The following is a description of a gene set: from publication Chen Y, Wang X (PMID 31504780) studied in species Homo sapiens Genes predicted to be targets of miRBase v22 microRNA hsa-miR-3191-5p in miRDB v6.0 with MirTarget v4 prediction scores > 80 (high confidence targets). Human Gene Set: MIR3191_5P, and this is the list of marker genes: PARP9, SHISA7 (shisa family member 7), RICTOR, KCNRG, MAPK1, TMEM70, ATXN1, BTRC (NCBI Gene Id 8945), ARCN1, SLC35B4, ADGRF1, MICAL2, DESI1, MYO1C, RNGTT, METTL25B, MTM1, ZSWIM5, TRIM39, CD34, MRAS, ARID5B, UNC5C (unc-5 netrin receptor C), ZNF322, EPHB3, FAS, CLCN5, WDHD1, DDHD1, SELENOI, AQP9, GLS2, CALCR (NCBI Gene Id 799), ALCAM (NCBI Gene Id 214), OTUD1, SLC2A5 (solute carrier family 2 member 5), CMKLR1, SDK2, IQCJ-SCHIP1, PCDH7, NSL1, XPO4, BBX, KCTD15, NFATC3, DPF2, ZNF839, TMPRSS11D, TRABD2B, MAT2A, CERS6, COL14A1, STRADA, SEZ6L, LAIR1 (NCBI Gene Id 3903), TAF12, AFG2A, MYO15A, RREB1, ATRN, DNAAF6, BEND6, ZDHHC3, ODR4, EYS, PDE1B, RUNDC3A, GPRC5B, ZFP1, TK2, FLRT3, PAX5, ENPP5, PRKCA, RNF185, CBLN2, FANCL, RASAL2, NGFR, BCAT1, GPD2, SCG3, SH2B3, ARPP21, PCNX1, BRCC3, PTPN3, SLC24A3, TMF1, TAF1B, EPB41L1, CNDP1, FBXO3, SCHIP1, DYNLL1, PLXNA2, IMPACT, KIAA1958, A1CF, BAALC, USP3, CTSE, KAT6A, RBFOX2, MSI2, FBXO21, C5orf22, PTBP1, ATP6V1C2, NAF1, CADM2, KLHL14, ZBTB7C, FAM13A, RFLNA, HMGN5, ZZEF1, VTI1A, ZNF781, POTEM, PDS5A, SLC38A2 (NCBI Gene Id 95454), NUBPL, ATP2A2, SRP19, BIN2, ASPH, SYT13, NR5A1, ZNF268, SMIM7, RPE65, FGF1, PALM, JAKMIP3, CRB1, SH3PXD2A, ZNF396, NADK2, HS3ST5, STK36, ID1, KIAA1328, GOSR1, TNK2, ARMH3, ELK1, HMGXB4, ANKRD45, TAP2, PTER, GRM1, AGBL3 (AGBL carboxypeptidase 3), MGA, PCNP, SGSM1, JAKMIP2, RBM44, NRAS, ITGA5, ERC1, CDH6